The following is a description of a gene set: studied in species Homo sapiens The covalent attachment of a palmitoyl group to a protein. Human Gene Set: GOBP_PROTEIN_PALMITOYLATION, and this is the list of marker genes: ZDHHC3, ZDHHC15, ZDHHC19, ZDHHC20, ZDHHC23, ZDHHC14, HHATL, ZDHHC11, ZDHHC21, ZDHHC16, ZDHHC2, SELENOK, ZDHHC5, ZDHHC22, CLIP3 (NCBI Gene Id 25999), ZDHHC8, HHAT, ZDHHC9, GLUL, ZDHHC17, GOLGA7, ZDHHC7, ZDHHC12, ZDHHC6, ZDHHC18, ZDHHC1